Given this list of marker genes GPN3, BPI, CCDC115, DAAM2, BDNF, ALX1, EXOC2, BAHD1, ALX4, CDK5RAP2, FBXL14, H2BC1, LINC02210, SAXO4, TMA7, AK9, COG1, DNAH12, CA8, CUBN, H1-5, TRAPPC11, ERP29, BAALC-AS2, CD46, ARSJ, PRDM16-DT, DEPTOR, CC2D1B, GUF1, PAGR1, CD40LG, ABHD1, LINC00951, CABLES1, ADCY9, CDS1, CAMSAP2, EEF1E1, GPX7, OGFOD3, APOL6, CACNG7, ATP13A5, COPG2, CCDC28B, CD8B, HELZ, GPC3, CR2, AGRN, DACT1, FAM181B, EML3, CAPZA3, CSTA, HSD17B2, GJB3, COL6A6, CETN2, DLX1, FGF23, ANKMY1, HDAC7, ZGRF1, CCL4, CMTM5, DGCR5, DLL3, BBOX1, CSNK1D, LINC01949, DMTN, C9orf40, IBSP, BCL11A, DNAJA4, DDAH2, HRK, GSTM4, ACOT6, ENPP3, ALKBH7, CITED4, BBS1, CEP68, ZBTB7C-AS2, FBXO46, CRBN, C2CD2, COX7A1, ANKRD45, CXXC1P1, BID, CYP2J2, CNNM4, BEND4, ALMS1P1, GUCY1A1, HTR5A, GABARAPL3, CNPY1, BMS1P1, HSD17B1, BOLA3, GABRR3, FUS, AP4B1, GMNC, IFI44L, ECI2, EFCAB10, DUS1L, CLTCL1, GCAT, EVX1, GPC2, CHRNB2, FAM86C1P, HPD, CALCA, FAM47A, ETV6, CABP2, CFAP298, AFAP1, CCDC15, ADAMTSL3, CXCL14, C4orf36, GTF2H1, ACVR2A, PXYLP1, GUSBP11, CCS, ALK, CGNL1, LINC02880, CREB3L4, HNRNPA2B1, ANO8, HMX2, SUCO, EP400P1, FAAP100, CCDC180, CPNE3, CHD9, MTRES1, IDO1, ECM1 (extracellular matrix protein 1), GRIN3B, CNOT4, SOWAHA, CCNY, FRAT2, LINC01588, EIF3K, COL10A1, CHKA, DUS4L, ARHGEF19, ARHGEF16, DHX58, ETS1, CHRNG, DMBX1, CD248, DUSP14, DPYS, ARPIN, CACNA1A, EPM2AIP1, GASK1B, LINC03040 (long intergenic non-protein coding RNA 3040), ANKRD34A, GRAP, EIF2AK3, CLCN3, EEF1D, EVL, HARS1, BLCAP, CAMK1D, FAM111B (NCBI Gene Id 374393), MFSD12, C1QTNF7, MCUB, BCDIN3D, ZNF736, DOHH, CHRNA2, SMG8, here is a description of the gene set: Genes up-regulated in comparison of naive CD4 T cells versus activated regulatory T cell (Treg). studied in species Homo sapiens Human Gene Set: GSE15659_NAIVE_CD4_TCELL_VS_ACTIVATED_TREG_UP from publication Miyara M, Yoshioka Y, Kitoh A, Shima T, Wing K, Niwa A, Parizot C, Taflin C, Heike T, Valeyre D, Mathian A, Nakahata T, Yamaguchi T, Nomura T, Ono M, Amoura Z, Gorochov G, Sakaguchi S (PMID 19464196) Gene expression profiles of subsets of CD4+ T cells according to their expression of FoxP3 and CD45RA were compared. FoxP3 is a key transcription factor for the development and function of natural CD4+ regulatory T cells (Tregs). Here we show that human FoxP3+CD4+ T cells are composed of three phenotypically and functionally distinct subpopulations: CD45RA+FoxP3low resting Tregs (rTregs) and CD45RA-FoxP3high activated Tregs (aTregs), both of which are suppressive in vitro, and cytokine-secreting CD45RA-FoxP3low non-suppressive T cells. The proportion of the three subpopulations characteristically altered in cord blood, aged individuals, and patients with immunological diseases. Terminally differentiated aTregs rapidly die while rTregs proliferate and convert into aTregs in vitro and in vivo as shown by the transfer of rTregs into NOD-scid-common gamma-chain-knockout mice and by TCR sequence-based T cell clonotype tracing in peripheral blood of normal individuals. Taken together, the dissection of FoxP3+ cells into subsets enables one to analyze Treg differentiation dynamics and interactions in normal and disease states, and to control immune responses through manipulating particular FoxP3+ subpopulations.